The following is a description of a gene set: studied in species Homo sapiens Hypoplastic/small or absent thumb. Human Gene Set: HP_APLASIA_HYPOPLASIA_OF_THE_THUMB Aplasia/Hypoplasia of the thumb, and this is the list of marker genes: BCOR, CHST11, ADAMTS10, SON, RFWD3, RPS26, PCNT, LETM1 (leucine zipper and EF-hand containing transmembrane protein 1), SMC1A, SF3B4, RPL15, PALB2, MAP3K7, LIG4, KDM1A, RIPK4, KNSTRN, RNU4ATAC, FZD2, FGFRL1, RPS28, LTBP2 (latent transforming growth factor beta binding protein 2), GNAS, NSUN2, CUL3, RAD51C, FLNA, PSMD12, TP63, ROBO1, LMNB2, DONSON, CREBBP, EP300, LRP4, BRIP1, FGFR2, FGFR1, PTCH1, FGFR3, ERI1, SOX9, ADAMTS17, RPS29, SLC26A2, FANCI, RPL11, ADA2, RPS20, RPL5 (NCBI Gene Id 90045), HDAC8, MED12, RAD51 (NCBI Gene Id 5888), ERCC4, FANCF, SVBP, XRCC2, MAFB (NCBI Gene Id 9935), IHH, SETBP1, CPLX1, RPS15A, SRCAP, LMBR1 (limb development membrane protein 1), HOXA13, FANCE, RPL35, DLK1, RPS19 (ribosomal protein S19), DHODH, PIGG (NCBI Gene Id 54872), FIG4 (FIG4 phosphoinositide 5-phosphatase), KCNH1, RPL8, RPL26, CHD7, TAF6, VPS35L, HEATR3, BMPR1B (bone morphogenetic protein receptor type 1B), PIK3CD, ACAN, REV3L, RPS7, CTBP1, RAD21, RTL1, NSD2, BICRA, UBE2T, GATA1, ACVR1, TRIO, DHCR7, SMC3, ZMYM2, FGF10, NIPBL, RPS17, NELFA, SLX4, MGP, WIPI2, CANT1, FANCA, MIR17HG, ATP6V1B2, APC, RPL27, PLXND1, TSR2, ZNF699, BHLHA9, RPL9, RPS10, RPL18, TBX5, GDF5, FANCC, RBM8A, FANCL, VAC14, BRCA2, MEG3, CHN1, RECQL4, TFAP2A (NCBI Gene Id 95131), RB1, RPL35A, MYCN, TRPM3, RPS24, SIN3A, NOG, BRD4, RPL31 (NCBI Gene Id 6160), FANCB, SALL4, LAMA5, SHH, RSPO2, COL2A1, ESCO2, EIF4A3, PKDCC, FANCD2, FBN1, FRAS1, RPS27 (ribosomal protein S27, NCBI Gene Id 6232)